Given this list of marker genes EMP2, TGFBR2, NOTCH1, TGFB1, TGFBR1, TGFB2, NOG, JAG1, TWIST1, TGFB3, MIR19A, ENG, MIR19B1, ACVR1, here is a description of the gene set: studied in species Homo sapiens Human Gene Set: GOBP_REGULATION_OF_CARDIAC_EPITHELIAL_TO_MESENCHYMAL_TRANSITION Any process that modulates the rate, frequency or extent of cardiac epithelial to mesenchymal transition, a transition where a cardiac epithelial cell loses apical/basolateral polarity, severs intercellular adhesive junctions, degrades basement membrane components and becomes a migratory mesenchymal cell.